Given this list of marker genes PLB1, MYCL, CCR2, S100A8, CLEC4A, CLEC7A, HK3, CD163, MPEG1, CIITA, TYROBP, CD300LF, LRRC25, HLA-DQA2, SLC24A4, LINC01094, CCDC26, HLA-DPA1, C5AR1, NLRC4, MNDA, PLD4, P2RY13, SCIMP, EGR2, HLA-DRB1, C1QC, MS4A4E, PADI2, MARCO, SPNS3 (NCBI Gene Id 201305), MPO, FPR1, FCN1, CLEC4GP1, NCF2, C1QA, NFAM1, SIGLEC11, TLR2, LGMN, C3AR1, FLT3, LINC02712 (long intergenic non-protein coding RNA 2712), TIMD4, HLA-DRB5, DEFA3, CLEC4F, SIGLEC14, RBM47, CLEC5A, CCR1, CSTA, SPP1, C1QB, HLA-DQA1, CD14, AZU1, SOWAHD, ADAM28, ENSG00000227531, FGD2, TLR7, CD1E, LINC00278, TLR8, MMP9 (NCBI Gene Id 4318), CYP2S1, CCL22, FGL1, IGSF6, LILRB3, XCR1, HLA-DRB6, PRTN3, SPI1, LRRK1, LILRB5, SMIM35, IL1RN, SIRPB2, LYZ, LINC01605, CSF1R, TMEM106A, LINC03070, SLAMF8, SIRPB1, UPK3A, VSIG4, NOD2, MS4A14, SLC37A2, PDCD1LG2, CD209, TREM2, IRF8, OSCAR (osteoclast associated Ig-like receptor), MS4A6A, MS4A4A, NAPSB, LILRB1, IDO2, EBI3, PILRA, CD1D, CSF2RA, ITGAX, GPR34, PLA2G7, HLA-DRA, HCK, ANO7L1, MS4A7, C19orf38 (chromosome 19 open reading frame 38), SLC38A6, SLC11A1 (NCBI Gene Id 6556), CLEC10A, CYBB, CD163L1, JAML (junction adhesion molecule like), CD74, ACP3, RBPJ, LINC00996 (long intergenic non-protein coding RNA 996), LILRA1, ENSG00000253557, NRIR, SLCO2B1, LILRB4, HLA-DMB, P2RY6, CD86, IL1R2, SIGLEC1, ENSG00000231873, CLEC9A, WFDC21P, here is a description of the gene set: Marker genes curated from the annotated cluster as represented in the Descartes Human Gene Expression During Development database. Human Gene Set: DESCARTES_FETAL_HEART_MYELOID_CELLS The gene expression program underlying the specification of human cell types is of fundamental interest. The study authors generated human cell atlases of gene expression and chromatin accessibility in fetal tissues. For gene expression, the study authors applied three-level combinatorial indexing to >110 samples representing 15 organs, ultimately profiling ~4 million single cells. The study authors leveraged the literature and other atlases to identify and annotate hundreds of cell types and subtypes, both within and across tissues. Our analyses focused on organ-specific specializations of broadly distributed cell types (such as blood, endothelial, and epithelial), sites of fetal erythropoiesis (which notably included the adrenal gland), and integration with mouse developmental atlases (such as conserved specification of blood cells). These data represent a rich resource for the exploration of in vivo human gene expression in diverse tissues and cell types. from publication Cao J, O'Day DR, Pliner HA, Kingsley PD, Deng M, Daza RM, Zager MA, Aldinger KA, Blecher-Gonen R, Zhang F, Spielmann M, Palis J, Doherty D, Steemers FJ, Glass IA, Trapnell C, Shendure J (PMID 33184181) species: Homo sapiens